Given this list of marker genes Irf8, Lyar, AU020206, Irgm1, Gbp5, Serpina3g, Irf1, Fbrsl1 (fibrosin-like 1), Tap1, Stat1, Igtp, Samhd1, Erap1, Socs1, Gbp7, here is a description of the gene set: Cytokines mediate cell-cell communication in the immune system and represent important therapeutic targets. A myriad of studies have highlighted their central role in immune function, yet we lack a global view of the cellular responses of each immune cell type to each cytokine. To address this gap, the authors created the Immune Dictionary, a compendium of single-cell transcriptomic profiles of more than 17 immune cell types in response to each of 86 cytokines (>1,400 cytokine-cell type combinations) in mouse lymph nodes in vivo. A cytokine-centric view of the dictionary revealed that most cytokines induce highly cell-type-specific responses. For example, the inflammatory cytokine interleukin-1β induces distinct gene programmes in almost every cell type. A cell-type-centric view of the dictionary identified more than 66 cytokine-driven cellular polarization states across immune cell types, including previously uncharacterized states such as an interleukin-18-induced polyfunctional natural killer cell state. Genes positively differentially expressed in cell type: B cell upon treatment with cytokine: IL-2 in mouse lymph nodes in vivo. studied in species Mus musculus from publication Cui A, Huang T, Li S, Ma A, Pérez JL, Sander C, Keskin DB, Wu CJ, Fraenkel E, Hacohen N (PMID 38057668) Mouse Gene Set: CUI_B_CELL_IL2_RESPONSE_UP